Given this list of marker genes Gnai2, Scamp5, Doc2b, Stxbp3, Syt7, Zp3, Arf1, Rph3a, Doc2g, Cacna1h, Stx1b, Myh9, Cdk5r2, Rims3, Sdf4, Rph3al, Pou5f1, Cdk5, Syt8, Cltrn, Hyal3, Unc13d, Vamp3, Cacna1c, Syt12, Arl8b, Kcnb1, Cadps, Rims1, Cacna1a, Rab3a, Notch1, Nlrp5, Baiap3, P2rx7, Arhgap17, Syt11, Tspan18, Syt3, Stxbp2, Syt5, Syt2, Syt10, Syt15, Snap25, Stx1a, Rab3gap1, Syn2, Rap1b, Vamp2, Vamp8, Syt13, Atp2a2, Orai1, Rims2, Unc13c, Snapin, Cadps2, Unc13b, Syt9 (NCBI Gene Id 60510), Syt6, Eqtn, Rapgef4, Ppp3cb, Stxbp1, Trim9, Syt1 (synaptotagmin I), Syt4, Rest, Cbarp, Unc13a, Adra2a, Syt17, Cacna1g, Cacna1i, Doc2a, here is a description of the gene set: studied in species Mus musculus The release of intracellular molecules (e.g. hormones, matrix proteins) contained within a membrane-bounded vesicle by fusion of the vesicle with the plasma membrane of a cell, induced by a rise in cytosolic calcium-ion levels. Mouse Gene Set: GOBP_CALCIUM_ION_REGULATED_EXOCYTOSIS